The following is a description of a gene set: Transcription factors of the NF-kappaB family regulate hundreds of genes in the context of multiple important physiological and pathological processes. NF-kappaB activation depends on phosphorylation-induced proteolysis of inhibitory IkappaB molecules and NF-kappaB precursors by the ubiquitin-proteasome system. Most of the diverse signaling pathways that activate NF-kappaB converge on IkappaB kinases (IKK), which are essential for signal transmission. Many important details of the composition, regulation and biological function of IKK have been revealed in the last years. This review summarizes current aspects of structure and function of the regular stoichiometric components, the regulatory transient protein interactions of IKK and the mechanisms that contribute to its activation, deactivation and homeostasis. Both phosphorylation and ubiquitinatin (destructive as well as non-destructive) are crucial post-translational events in these processes. In addition to controlling induced IkappaB degradation in the cytoplasm and processing of the NF-kappaB precursor p100, nuclear IKK components have been found to act directly at the chromatin level of induced genes and to mediate responses to DNA damage. Finally, IKK is engaged in cross talk with other pathways and confers functions independently of NF-kappaB. species: Homo sapiens from publication Scheidereit C (PMID 17072322) Human Gene Set: SCHEIDEREIT_IKK_TARGETS Genes encoding substrates of IkappaB kinase (IKK) complex., and this is the list of marker genes: CCND1, H3C15, NCOR2 (NCBI Gene Id 9612), BCL10, NCOA3, NFKB1, FOXO3, CYLD, NFKBIB, ESR1, RELA, YWHAB, NFKBIA, DOK1, CTNNB1, NFKBID, NFKB2, IRS1